Given this list of marker genes QPRT, PRSS8, ATF3, SDC4, AREG, GSN, BIRC3, MAP1LC3B, LY6E (lymphocyte antigen 6 family member E), PSG11 (pregnancy specific beta-1-glycoprotein 11), RCAN1, TXNIP, PLAUR, NEU1, HLA-E, ISG20, ST3GAL5, GADD45A, ITGA2, ARF4, EVX2, TFPI2, SERPINE1, BECN1 (NCBI Gene Id 8678), COL1A1 (collagen type I alpha 1 chain), TAP1, LGALS9, CAMSAP2, SLPI, DUSP6, PRDX5 (peroxiredoxin 5), MFGE8, PON2, CD9, IFNGR1, ATP6V0E1, KDM2A (NCBI Gene Id 22992), RRBP1, YPEL5, SCAMP2, MAP2K3, CTSB, BLZF1, H2AC21, S100P, TNFAIP2, ISG15, ARL6IP5, PPT2, CD55, P4HA2, PAGE1, DNAJB2, BST2, PISD, PSEN1, IGFBP3, PLAT, RAB9A, CDKN1A, SLC6A8, LDAF1, PSG1, IL23A, MYRIP, SSX4, MXD4, RNF103, OAS1, MELTF, DUSP5, DUSP1, PANX1, SAT1, OAS2, ACSS1 (NCBI Gene Id 89850), STAT1, SOD2, CTSL, PTGS2, CDC123, H2AC6, TIMP1, LCN2, IL32, CTAG1B, LGMN, PSAP, TMEM59, MIR22HG, SUSD6, IFIT1, TNFAIP3, PERP, MMP15, ATP6V1G1, SP110, HYAL1, SPINT1, UBD, TRIM21, BCL11A, POLD4, GRK4, GRN, ATP1B1, CCS, MAGEC1, SQSTM1, ATOX1, H2BC12, WFDC2, RBM38, USP9X, CCL20, TMEM184B, RARRES1, IGF2, UBE2H, UBE2L6, PMEL, MX2, IFI44L, IL1B, TACSTD2, here is a description of the gene set: Genes up-regulated in PaCa44 and CFPAC1 cells (pancreatic cancer) after treatment with decitabine, a DNA hypomethylating agent similar to azacitidine. studied in species Homo sapiens from publication Missiaglia E, Donadelli M, Palmieri M, Crnogorac-Jurcevic T, Scarpa A, Lemoine NR (PMID 15637593) Human Gene Set: MISSIAGLIA_REGULATED_BY_METHYLATION_UP Alteration of methylation status has been recognized as a possible epigenetic mechanism of selection during tumorigenesis in pancreatic cancer. This type of cancer is characterized by poor prognosis partly due to resistance to conventional drug treatments. We have used microarray technology to investigate the changes in global gene expression observed after treatment of different pancreatic cancer cell lines with the methylase inhibitor 5-aza-2'-deoxycytidine (5-aza-CdR). We have observed that this agent is able to inhibit to various degrees the growth of three pancreatic cancer cell lines. In particular, this inhibition was associated with induction of interferon (IFN)-related genes, as observed in other tumour types. Thus, expression of STAT1 seems to play a key role in the cellular response to treatment with the cytosine analogue. Moreover, we found increased p21(WAF1) and gadd45A expression to be associated with the efficacy of the treatment; this induction may correlate with activation of the IFN signalling pathway. Expression of the p16(INK) protein was also linked to the ability of cells to respond to 5-aza-CdR. Finally, genome-wide demethylation induced sensitization that significantly increased response to further treatment with various chemotherapy agents.